Given this list of marker genes MPDU1, FECH, IPO8 (NCBI Gene Id 10526), ABCC9, COMT, TNFRSF1B, CDSN, SLF2, IKBKG, STAT5B, AIP, ERCC3, DPP9, STAT6, RNF31, IL7R, DNAJC21, TOM1, SIK3, ZNF341, RTTN, NCF2, RRAS2, NFKBIA, NOD2, LBR, SRD5A3, RBCK1, PIGA, SRCAP, FOXN1, IL17RA, LIG4, NSMCE3, ASL, ARVCF, AUTS2, FLI1, DDX41, SLC19A1, HDAC4, RREB1 (ras responsive element binding protein 1), CYBB (cytochrome b-245 beta chain), GNB2, NCF4, PPOX, CARS1, ADA2, SCNN1A, RNF113A, HIRA, TPR, NRAS, TMC6, LGI3, SUOX, BTD, FOXP3, LZTR1, PGM2L1, SLC39A7, FLG, ZAP70, SHOC2, CARMIL2, PGM3 (NCBI Gene Id 5238), RAC1, WAS, MAP2K1 (mitogen-activated protein kinase kinase 1), DOCK8, WIPF1, SMARCC2, NCF1, MBTPS2, MSN, SPINK5, C5, CYBA, MCCC2, EDAR, CST6 (cystatin E/M), HLA-DQA1, RFX7, DRG1, IGHG2, TBCK, KDF1, HR, PEPD, IL6R, CSTA, TAF1, CIB1, GNA11, CD3G, TP63, MTHFD1, PCCB, HLA-DQB1, CASP8, TBC1D2B, GINS1, TRAF3IP2, ZNF750, KARS1, PRMT7, KANSL1, CAMK2B, IL6ST, PCCA, SLCO2A1, NUP107, SMG8, TKT, BRAF, GGT1 (gamma-glutamyltransferase 1), ARPC5, DHCR7, IL2RA (NCBI Gene Id 3559), EDA, NAA10, RBM8A, JAK1, FOCAD, H3-3B, GPR101, CYBC1, PIK3CA, TRAF6, CD28, PIK3CG, NEK9, CFTR, IFIH1, NBEA, SBDS, SMARCA2, ERCC2, STAT3, GTF2E2, CARD14, MPLKIP, HPGD (15-hydroxyprostaglandin dehydrogenase), HSPA9, SCNN1B, EDARADD (EDAR associated via death domain), FLG2, TMC8, SLC30A2, KRT74, MORC2, SCNN1G, LYN, UFD1, RNU12, TGM5, LIG1, KRT1, EFL1, LRRC32, SEC24C, TARS1, JMJD1C, HLA-DRB1, RNU4ATAC, MYSM1, IL7, GTF2H5, HLCS, CTLA4, CASR, CARD11, STAT1, SIN3A, POLE, RIT1, GP1BB, IGKC, AARS1, PAH, NSUN2, TBX1, NECTIN1, here is a description of the gene set: Human Gene Set: HP_ECZEMATOID_DERMATITIS Eczema is a form of dermatitis that is characterized by scaly, pruritic, erythematous lesions located on flexural surfaces. Eczematoid dermatitis species: Homo sapiens